Given this list of marker genes SOD2, E2F3 (E2F transcription factor 3), IGF1, SLC7A5, ADCY10, PPARG, DNMT1, PDCD4, MIR24-1, ATF4 (NCBI Gene Id 468), MIR1-1, MIR210, MIR21, MIR140, MIR17, RBM10, MFN2, MIR138-1, here is a description of the gene set: Any apoptotic process in a vascular associated smooth muscle cell. species: Homo sapiens Human Gene Set: GOBP_VASCULAR_ASSOCIATED_SMOOTH_MUSCLE_CELL_APOPTOTIC_PROCESS